Given this list of marker genes GALR3, IDE, HCRTR2, GLP2R, GHRHR, INHBA, RXFP2, CALCRL, IL23R, PRLR, GALR2, INSR, SCTR, GIPR, CRHR2, IGF1R, NPR1, GALR1, VIPR2, CALCR, RAMP1, CCKAR, MC3R, PTH2R, GCGR, CSF2RA, VIPR1, APP, SLC40A1, HCRTR1, GHSR, ADCYAP1R1, GHR, EDNRB, NPY4R, RAMP2, ECE1, CRHBP, FSHR, LEPR, CRHR1, CMKLR1, AVPR1A, CCKBR, NPR3, GLP1R, PTH1R, C2CD2L, CMKLR2, PIK3R1, ACVR1, NPR2, here is a description of the gene set: studied in species Homo sapiens Binding to a peptide with hormonal activity in animals. Human Gene Set: GOMF_PEPTIDE_HORMONE_BINDING